Given this list of marker genes Esyt2, Gramd2a, Esyt3, Vapb, Vapa, Esyt1, here is a description of the gene set: The attachment of an endoplasmic reticulum membrane to the plasma membrane via molecular tethers. studied in species Mus musculus Mouse Gene Set: GOBP_ENDOPLASMIC_RETICULUM_PLASMA_MEMBRANE_TETHERING